Given this list of marker genes Slc2a4, Slc45a2, Slc45a4, Slc45a1, Slc45a3, here is a description of the gene set: species: Mus musculus Enables the transfer of a solute or solutes from one side of a membrane to the other according to the reaction: carbohydrate(out) + H+(out) = carbohydrate(in) + H+(in). Mouse Gene Set: GOMF_CARBOHYDRATE_PROTON_SYMPORTER_ACTIVITY